Given this list of marker genes Gnb2, Gng10, Gng11, Gngt2, Gng4, Cdc42, Gnb5, Gng5, Gng8, Gngt1, Gnb3, Plcb3, Gng3, Gng7, Pik3r5, Pdpk1, here is a description of the gene set: electronically inferred by orthology from the curated human pathway This event has been computationally inferred from an event that has been demonstrated in another species.<p>The inference is based on the homology mapping from PANTHER. Briefly, reactions for which all involved PhysicalEntities (in input, output and catalyst) have a mapped orthologue/paralogue (for complexes at least 75% of components must have a mapping) are inferred to the other species. part of: GPCR downstream signalling species: Mus musculus Reactome Pathway: G-protein beta:gamma signalling